The following is a description of a gene set: Any process that activates or increases the frequency, rate or extent of the chemical reactions and pathways resulting in the formation of cholesterol. species: Mus musculus Mouse Gene Set: GOBP_POSITIVE_REGULATION_OF_CHOLESTEROL_BIOSYNTHETIC_PROCESS, and this is the list of marker genes: Qki, Abcg1, Prkaca, Abcg4, Npy1r, Fgf1, Srebf1, Gnai1, Sec14l2, Fdps, Por, Paqr3, Mapk1, Cyp7a1, Scp2, Srebf2, Mbtps2, Scap